Given this list of marker genes DDA1, GID4, PRAMEF8, PRAMEF22, SEL1L, ARMC8, CDC27 (cell division cycle 27), PCGF5, ZER1, RING1, RCHY1, PRAMEF26, FBXO42, KLHL7, KLHL29, DCAF12L1, WDR26, SMURF2, DCAF10, SYVN1, DCAF12, DCUN1D3, KLHDC1 (NCBI Gene Id 122773), ZSWIM6, CUL1, RNF217, UBE2S, FBXO8, DTL, MGRN1 (NCBI Gene Id 23295), KLHL24, PRAMEF2, FBXL12, UBR2, PRAMEF20, RNF2, ELOC, TNFAIP1, APPBP2, UBR1, FBXL17, BRAP, CUL4B, UBE4B, KLHL4, NEDD4, PCGF6, FBH1, PCGF3, KBTBD7, RNF11 (ring finger protein 11), ANKIB1 (ankyrin repeat and IBR domain containing 1), DCAF8L1, PRAMEF5, GLMN, ZYG11A, ZYG11B, HERPUD1, FBXL19, KLHL21, IPP (intracisternal A particle-promoted polypeptide), PRAMEF12 (NCBI Gene Id 649289), MAEA, FBXO6, SAMD7, RNF168, RNF144A, RAD51, DCAF4, DCAF17, BCOR, RNF19A, FBXW4, WDTC1, MED30, SOCS2, RANBP10, SPOP, DCUN1D2, DCAF8, ERCC8, PHC2, PHC1, MIB2, FBXO10, FBXL5 (NCBI Gene Id 26234), SKP1, MED27, CCNF, PRAMEF33, ANAPC2, AMFR, FBXW11, MED7, CBX8, FBXO4, DYRK2, DDB2, KLHL13, CUL2, FBXO21, FBXL15, FBXO32, FBXO7, PRKN, ANAPC7, UBXN8, ASB12, SUGT1, ZSWIM4, SPSB1, ARIH1, KLHL23, MED21, WWP2, KLHL5, BRCC3, IVNS1ABP, MARCHF6, ENC1, DCUN1D1, DDB1, PRAMEF19, KLHL17, PCGF2, CBLL1, PRAMEF10, FBXO3, DCAF11 (DDB1 and CUL4 associated factor 11), CAND1, NCCRP1, FBXO39, CDC20B (NCBI Gene Id 166979), MED6, ANAPC11, BUB1B, ANAPC4, KLHL35, ANKRD9, ARMC5, FBXL21P, FEM1A, TOPORS (TOP1 binding arginine/serine rich protein, E3 ubiquitin ligase), MEGF8, FAM8A1, TRAF7, PRAMEF4, MED11, UBE2E1, TRPC4AP, KCTD5, ASB9, FEM1B, UBE2N, FBXL2, DAW1, KLHL30, RNF40, ANAPC16, KLHL2, DCAF8L2, PRAME (PRAME nuclear receptor transcriptional regulator), FBXO9, RMND5A, ZSWIM5, MED8, RBX1 (ring-box 1), KBTBD12 (kelch repeat and BTB domain containing 12), KLHL18, STUB1, KBTBD8, KLHL11, RNF7, UBAC1, MED12, PRAMEF7 (NCBI Gene Id 441871), FBXL13, RNF144B, CUL4A (NCBI Gene Id 8451), IKBKG, TRIM21, FBXO11, CBX4, UBE2J1, KCTD13, FBXO15, KLHL40, DCAF15, PRAMEF17, DCAF1, RNF20, BARD1, KLHL12, CBX2, PRAMEF14, DCAF4L2, CDC16, OTULIN, PRAMEF15, FBXW8, YPEL5, PCGF1, KBTBD3, ASB1, USP33 (NCBI Gene Id 23032), KLHDC2, UBE3D, UBE2L3, DEPDC5, WWP1, TRAF2, AMN1, KLHL20, CBX7, TMEM183A, FBXW5, UBE2B, DMAC2 (NCBI Gene Id 55101), FBXO38, FBXO46, RNF19B, BMI1, FBXO31, FEM1C, BRCA2, ASB2, FBXO17, UBE2U, KLHDC3, OS9, CUL3, SOCS7, CDC20, PEF1, ANAPC13, MKLN1, CBX6, FBXW7, DCAF4L1, WDR77, DCAF6, PRAMEF1, KLHL41, CUL5, KLHDC10, ANAPC10, MAVS, SHARPIN (NCBI Gene Id 81858), CUL9 (cullin 9), PHC3, FBXO27 (F-box protein 27), SPSB4, ELOB, KCTD10, FBXO45, FBXL20, CKS1B, DCAF13, RMND5B, CKS2, SPSB2, FBXL7, KLHL6, UBE2V1, LMO7, KLHL10, RBCK1, ASB11, ANAPC15, UBE4A, DCUN1D5, CDC23, KBTBD2, BTRC, FBXL4, CUL7, CDKN1B, BABAM2, TRAF3 (NCBI Gene Id 7187), PRAMEF13, RNF31, PRAMEF9, COP1, KCTD17 (NCBI Gene Id 79734), MED1, MED17, SKP2, COMMD1, UBE2J2, GPR37, DCAF16, KLHL1, MAD2L2, DCAF12L2, PRAMEF18, ASB4, RAD18, DCAF7, SPSB3, FBXO25, CDC26, MED31, CRBN, FZR1, KLHL15, SAMD11, CCIN, RNF8, LRRC75A (leucine rich repeat containing 75A), RNF14, KLHL3, AMBRA1, PRAMEF27, UBR3, ANAPC5, KLHL8, FBXL6 (NCBI Gene Id 79606), FBXO24, KLHL42, FBXL16, KEAP1, PCMTD1 (protein-L-isoaspartate (D-aspartate) O-methyltransferase domain containing 1), KCTD2, ARIH2, DCUN1D4, RANBP9, LZTR1 (NCBI Gene Id 8216), DET1, PRAMEF25, MED10, KLHL25, KLHL9, FBXO48, KLHL38, KLHL28, FBXL3, UBE2C, GAN, PRAMEF6, SPOPL, FBXL14, KLHL22, CACYBP, UBE2A, ANAPC1, KBTBD6, BRCA1, FBXO2, USP47, ABTB1, DCAF5, ZSWIM8, PDCD6, FBXO44, TMEM183BP, PRAMEF11, GID8, here is a description of the gene set: studied in species Homo sapiens Human Gene Set: GOCC_UBIQUITIN_LIGASE_COMPLEX A protein complex that includes a ubiquitin-protein ligase and enables ubiquitin protein ligase activity. The complex also contains other proteins that may confer substrate specificity on the complex.